Given this list of marker genes CD320, MTRR (NCBI Gene Id 4552), CBLIF, TCN1, TCN2, MMACHC, MMAA, MMUT, CUBN, MMADHC, MTR, AMN, MMAB (metabolism of cobalamin associated B), here is a description of the gene set: Human Gene Set: WP_VITAMIN_B12_DISORDERS species: Homo sapiens Vitamin B12 disorders